Given this list of marker genes IFITM1, IFI6, IFIT1, STAT1, ISG15 (NCBI Gene Id 9636), PSMB9, IFNGR1, IFI16, IRF7, IFIT3, OAS1, PSMB10, IFI35, IRF1, MX1 (MX dynamin like GTPase 1), IFIT2, PSMB8, here is a description of the gene set: from publication Bowie ML, Troch MM, Delrow J, Dietze EC, Bean GR, Ibarra C, Pandiyan G, Seewaldt VL (PMID 17016442) Human Gene Set: BOWIE_RESPONSE_TO_EXTRACELLULAR_MATRIX studied in species Homo sapiens Genes up-regulated by growing HMEC-E6 cells (mammary epithelial cells damaged by expression of HPV-16 E6) in extracellular matrix (ECM). Interactions between extracellular matrix (ECM) and mammary epithelial cells are critical for mammary gland homeostasis and apoptotic signaling. Interferon regulatory factor-1 (IRF-1) is a transcriptional regulator that promotes apoptosis during mammary gland involution and p53-independent apoptosis. We have recently shown that rapid cell surface tamoxifen (Tam) signaling promotes apoptosis in normal human mammary epithelial cells that were acutely damaged by expression of human papillomavirus type-16 E6 protein (*HMEC-E6). Apoptosis was mediated by recruitment of CREB-binding protein (CBP) to the gamma-activating sequence (GAS) element of the IRF-1 promoter, induction of IRF-1 and caspase-1/-3 activation. Here, we show that growth factor-depleted, reconstituted ECM (rECM), similar to Tam, promotes apoptosis in *HMEC-E6 cells through induction of IRF-1. Apoptosis was temporally associated with recruitment of CBP to the GAS element of the IRF-1 promoter, induction of IRF-1 expression and caspase-1/-3 activation. Small interfering RNA-mediated suppression of IRF-1 protein expression in *HMEC-E6 cells blocked (1) induction of IRF-1, (2) caspase-1/-3 activation and (3) apoptosis. These observations demonstrate that IRF-1 promotes rECM-mediated apoptosis and provide evidence that both rECM and rapid Tam signaling transcriptionally activate IRF-1 through recruitment of CBP to the IRF-1 GAS promoter complex.